The following is a description of a gene set: from publication Xu Z, Potula HH, Vallurupalli A, Perry D, Baker H, Croker BP, Dozmorov I, Morel L (PMID 21543644) Human Gene Set: GSE23114_WT_VS_SLE2C1_MOUSE_SPLEEN_B1A_BCELL_UP studied in species Homo sapiens Sle2c1 is an NZM2410-derived lupus susceptibility locus that induces an expansion of the B1a cell compartment. B1a cells have a repertoire enriched for autoreactivity, and an expansion of this B cell subset occurs in several mouse models of lupus. Here we showed that expression of Sle2c1 enhances NZB cellular phenotypes that have been associated with autoimmune pathogenesis. A combination of genetic mapping and candidate gene analysis presents Cdkn2c, a gene encoding for cyclin kinase inhibitor p18INK4c (p18), as the top candidate gene for inducing the Slec2c1 associated expansion of B1a cells. A novel SNP in the Cdkn2c promoter is associated with a significantly reduced Cdkn2c expression in the splenic B cells and B1a cells from Sle2c1-carrying mice, which leads to defective G1 cell cycle arrest in splenic B cells and increased proliferation of Pc B1a cells. As cell cycle is differentially regulated in B1a and B2 cells, these results suggest that Cdkn2c play a critical role in B1a cell self renewal, and that its impaired expression leads to an accumulation of these cells with high autoreactive potential. Genes up-regulated in spleen B lymphocytes: wildtype versus lupus susceptibility locus Sle2c1., and this is the list of marker genes: PRR3, FEZ2, SS18L1, CYCS, UTP25, LRRFIP1, SERPINE2, GABPA, SPRY1, PPP2CA, IL1RAP, PLPP1, AHR, EIF4G2, NCOA4, SNRPG, TM9SF1, NOP56, MTHFD2, CDC42EP3, FAM98A, UMPS, PSMD14, PSMB5, PAQR3, PLAGL2, WDR47, IL1B, SP3, ATXN2, EZH2, RSAD2, CEP170, PAICS, ATF3, CLIC1, ATP6V1A, KDM6B, DIMT1 (DIM1 rRNA methyltransferase and ribosome maturation factor), LRRC8B (NCBI Gene Id 23507), CCND2, NELFE, GABPB1, LTBP4, HMGN4 (NCBI Gene Id 10473), PGAM1, POGZ, JRKL, HIVEP2, NFKB1, DUSP5 (NCBI Gene Id 1847), TMEM243, SLC26A2, UAP1, EEF1E1, VDAC3, LRRC42, PSMD9, TP53BP1, SPAG9, PEX3, NOL7, DUSP14, UTP3, MACF1, EIF2S1, HNRNPA0, UTP18, WDR43, GLIPR1, CD47, CALU, GNAI1 (G protein subunit alpha i1), S1PR1, ANKLE2, TARS1, ADAM17, RAB22A, COPS8, HAX1, FASLG, UTP14C, CCT6A (NCBI Gene Id 908), UBE2D1, ADAM19, C1orf216, IL18R1, SLC7A5, TXNDC9, MAP3K14, BCL10, CAND1, IPO7, PGK1, SYNCRIP, GNG5, PRDX3, GEM, ZPR1, EZR, IMMT, PRKD3, NPC1, PRPF18 (NCBI Gene Id 8559), BOLA2, ZC3H13, CA2, IRF4, CDS2, EBNA1BP2, STX1A, TNFSF14, HBEGF, ABCE1, SREBF2, ACTG1, ZNF267, LIG4, RPN2, ACSL1, CD40LG, SNAPC5, DPY19L2P2, RHOG, TERF1, CSTB, NAB1, IMPA1, SLC25A16, TFAM (NCBI Gene Id 8033), ATF1, SEC62, TUBG1, MLEC, MKLN1, DYNLL1, WNK1, ATP1B3, SRGN, COX17 (NCBI Gene Id 10063), HPS5, FKBP2, TNF, NFYA, LPCAT1, NFIL3, WSB2, GHITM, URB2, AIMP2, EIF4E (eukaryotic translation initiation factor 4E), QPCT, TXLNA, IPO5, ZNF195, BCL2A1, PEA15, PNP, MAK16, PSMD1, CHMP2A, AHCYL1, LYSET, CFLAR, EIF3J, RRAS2, HSBP1, FADD, CTSL, GTF2E2, PNO1, MAP2K3, CD48, EGR2, HNRNPAB, MRPL19, CD81, TUBB2A, RAD1 (RAD1 checkpoint DNA exonuclease), ATP2B1, PER2, SUB1, FUT4, PLP2, RNF14, CYTIP, CCT4, TUBA1B, CD200, SNAPC1, LCP2, NFE2L2, FEN1 (NCBI Gene Id 5882), DHX16, PRDX1, RRS1, WDR1, CALM2, PTPN22, ATP6V0A2